Given this list of marker genes CYP3A4, AKR7A3, ACY1, CYP3A5, CYP2A13, MGST1, AKR7A2, MGST2, ACY3, GGT6, DPEP1, GGT7, DPEP2, CYP1A2, AKR7L, GGT5, GGT1, MGST3, here is a description of the gene set: studied in species Homo sapiens Aflatoxin activation and detoxification Human Gene Set: REACTOME_AFLATOXIN_ACTIVATION_AND_DETOXIFICATION